The following is a description of a gene set: studied in species Homo sapiens Human Gene Set: WP_HOMOLOGOUS_RECOMBINATION Homologous recombination, and this is the list of marker genes: POLD1, RAD50, RAD54B, RPA1, NBN, BRCA2, ATM, MRE11, POLD2, POLD4, RAD52, POLD3 (DNA polymerase delta 3, accessory subunit), RAD51 (NCBI Gene Id 5888)